Given this list of marker genes Bmp5, Dgkq, Cyp11b1, Hsd11b2, Rest, H6pd, Bmp2, Cyp11b2, Cyp11a1, Wnt4, Cacna1h, Dkk3, here is a description of the gene set: species: Mus musculus The chemical reactions and pathways involving cortisol, the steroid hormone 11-beta-17,21-trihydroxypregn-4-ene-3,20-dione. Cortisol is synthesized from cholesterol in the adrenal gland and controls carbohydrate, fat and protein metabolism and has anti-inflammatory properties. Mouse Gene Set: GOBP_CORTISOL_METABOLIC_PROCESS